The following is a description of a gene set: The directed movement of glycerol across a membrane. Glycerol is 1,2,3-propanetriol, a sweet, hygroscopic, viscous liquid, widely distributed in nature as a constituent of many lipids. species: Homo sapiens Human Gene Set: GOBP_GLYCEROL_TRANSMEMBRANE_TRANSPORT, and this is the list of marker genes: AQP7B, AQP2, AQP3, AQP10, AQP1, AQP11, AQP9, AQP7